The following is a description of a gene set: In the endoplasmic reticulum, glycosyl transferases modify NOTCH precursors by glycosylating conserved serine and threonine residues in EGF repeats of NOTCH. <br><br> O-fucosyl transferase POFUT1 fucosylates NOTCH serine and threonine residues that conform to the consensus sequence C2-X(4-5)-S/T-C3, where C2 and C3 are the second and third cysteine residue within the EGF repeat, and X(4-5) is four to five amino acid residues of any type. <br> <br>O-glucosyl transferase POGLUT1, mammalian homolog of the Drosophila enzyme Rumi, adds a glucosyl group to conserved serine residues within the EGF repeats of NOTCH. The consensus sequence for POGLUT1-mediated glucosylation is C1-X-S-X-P-C2, where C1 and C2 are the first and second cysteine residue in the EGF repeat, respectively, while X represents any amino acid. Both fucosylation and glucosylation of NOTCH receptor precursors are essential for functionality. Reactome Pathway: Pre-NOTCH Processing in the Endoplasmic Reticulum studied in species Homo sapiens part of: Pre-NOTCH Expression and Processing, and this is the list of marker genes: POGLUT1, POFUT1, NOTCH2, NOTCH3, NOTCH4, NOTCH1 (NCBI Gene Id 54781)